The following is a description of a gene set: studied in species Homo sapiens Monocyte-derived dendritic cells (DC) and macrophages (MΦ) generated in vitro from the same individual blood donors were exposed to five different pathogens, and gene expression profiles were assessed by microarray analysis. Responses to Mycobacterium tuberculosis and to phylogenetically distinct protozoan (Leishmania major, L. donovani, Toxoplasma gondii) and helminth (Brugia malayi) parasites were examined, each of which produces chronic infections in humans yet vary considerably in the nature of the immune responses they trigger. Human Gene Set: GSE360_T_GONDII_VS_B_MALAYI_LOW_DOSE_DC_DN from publication Chaussabel D, Semnani RT, McDowell MA, Sacks D, Sher A, Nutman TB (PMID 12663451) Genes down-regulated in comparison of dendritic cells (DC) exposed to T. gondii versus DCs exposed to 5 worms/well B. malayi., and this is the list of marker genes: SLITRK5, CCL21, GPX3, TRAPPC3, ARHGAP26, FOS, VAMP8, NPTN, KTN1, POLR2G, VCL, HLA-E, GATD3, CIR1, AIFM1, BICD2, LRRTM2, F13A1, ADH5, RNH1, PLCG2, FKBP1A, CDH6, PKN1, PECAM1, GRIA3, MXRA5, CACNA1S, NDUFV2, CTNNAL1, CORO2A, SCGB1D2 (secretoglobin family 1D member 2), PNPLA6, CAMK1, ATP5PD, SULT1A1, LILRA2, STAB1, CPVL, CASR, ALOX5, FGL2, PLA2G15, APOC1, CHEK2, TNFSF12 (TNF superfamily member 12), HHEX, DCAF4, TGFA, OVOL2, IQCE, ZCCHC24, ALOX15, P2RY14, CAP1, TXNIP, RNF6, ITPR2, USP6, STX16, ST3GAL5, RCBTB2, ERF, ZNF592, CD52, ABCG1, LYL1, ITGB1BP1 (integrin subunit beta 1 binding protein 1), APOC2, STAC, RRH, CHN2, N4BP2L2-IT2, HGD, SORL1, MAPK14, WDR1, TKT, CD1A, AHCY, STX10 (syntaxin 10), MGST2, GGA2 (golgi associated, gamma adaptin ear containing, ARF binding protein 2), HFE, ADD1, KDM5D, BAG5, EVI5, ERP29, PIP4K2B, MRC1, ZMIZ2, RUNDC3B, DNASE2, CLEC3B (C-type lectin domain family 3 member B), SNX13, FRY, KRT8, ACTR3, ABCA6 (NCBI Gene Id 23460, ATP binding cassette subfamily A member 6), S100A4, HOXB13, BRPF1, DIS3, NXPH3, RGS19, IBSP, HR, HTT, MKRN1, FUCA1, FCER1A, NDUFS3, INTS10, MCAT, LAIR2, PAX5, PRCP, LPIN1, SAMM50, TGFBR2, TUSC2, SPON1, XRCC1, DOK2, MMP25, TMT1A, CTSK, LTA4H, KCTD12, FBXL5, BAP1, ATP5PO, MACROH2A1, MAF, PINK1, ALDH3A2 (aldehyde dehydrogenase 3 family member A2), CXCL12, FOLR2, ESYT1, NPRL2, C3AR1, LY86, DIAPH1, WIPF2, ATXN3, SYNE1, TPM1 (NCBI Gene Id 7168), IDH1, KRT15, MDM2, HEXA, AGPAT1, QPRT, ZNF81, PDZK1IP1, HSPA8, ATXN1, FKBP8, SLC1A5, KLHDC3, STK38, MNDA, CA4, OSBPL1A, LINC01587, P2RX1, NRG1 (neuregulin 1), DOCK2, ADORA3, ADCY7, LAMB2, CD1E, VASH1, HABP2, PRKACB, RIN2, LPCAT4, SLC6A3, PLG, POR (NCBI Gene Id 96440), ETV5, PNISR, CTNNA2, ADAM12, MID2, C6, CD1B, GFRA2, NRGN, UBL3, DXO, CBS (cystathionine beta-synthase), BTN3A1, CLIP2 (NCBI Gene Id 84805), RNASE6, LRP1, ZNF507, TLR5 (toll like receptor 5)